The following is a description of a gene set: Telomere C-strand synthesis initiation Human Gene Set: REACTOME_TELOMERE_C_STRAND_SYNTHESIS_INITIATION studied in species Homo sapiens, and this is the list of marker genes: PRIM2, TERF1, TINF2, TERF2, POLA1, POLA2, TERF2IP, POT1, CTC1, TEN1, PRIM1, STN1, ACD